The following is a description of a gene set: species: Homo sapiens Any process that decreases the rate, frequency, or extent of cartilage development, the process whose specific outcome is the progression of the cartilage over time, from its formation to the mature structure. Cartilage is a connective tissue dominated by extracellular matrix containing collagen type II and large amounts of proteoglycan, particularly chondroitin sulfate. Human Gene Set: GOBP_NEGATIVE_REGULATION_OF_CARTILAGE_DEVELOPMENT, and this is the list of marker genes: MIR21, CTSK (NCBI Gene Id 1513), EFEMP1, PTH, TGFBR1 (transforming growth factor beta receptor 1), GDF5, RFLNA, RFLNB, NKX3-2, FRZB, CCN4, ADAMTS12, BMP4, GREM1, RARG, PTHLH, RARA, RARB, NR5A2, ADAMTS7, SNAI2, WNT9A, SOX9, CHADL, IHH, NOG, WNT11, GLI3, LTBP3, LEP, CTNNB1, PTPN11, TGFB2